The following is a description of a gene set: Human Gene Set: GOMF_ALPHA_CATENIN_BINDING Binding to catenin complex alpha subunit. species: Homo sapiens, and this is the list of marker genes: CDH24, CDH2, PTPRT, VCL, PKP3, JUP, PKP2, CDH26, AJUBA, CTNNB1, NUMB